Given this list of marker genes PIK3CG, TRPM4, ADORA1, DMD, ATP1B1, MIR1-1, PKP2, PLN, JPH1, GJA5, CAV3, TRDN, KCNQ1, JPH2, NPPA, GSTM2, SLC8A1, NOS1, ATP1A2, GATA4, HRC, CALM1, MIR200C (NCBI Gene Id 406985), DSG2, P2RX4, PDE4B, CALM2, CAMK2D, RNF207, PDE4D, STC1, ACE2, ATP2A2, ZC3H12A, FKBP1B, ADCY10 (NCBI Gene Id 82259), MYH7B, ASPH, CASQ2, ATP2A1, SUMO1, PRKACA, CAV1, KCNJ2, CACNA1C, HCN4, MIR30E, CALM3, STRIT1, FKBP1A, SRI, RGS2, AKAP9, DLG1, MYBPC3, RANGRF, SCN5A, MIR448, FGF13, CHGA, CLIC2, CTNNA3, ADRA1B, BMP10, SMAD7, GSTO1, DSC2, EHD3, TMEM38B, BIN1, RYR2, UCN, JPH4, HSP90AA1, SCN10A, DSP, MIR133A1, TNNI3K, NKX2-5, TNNI3, JUP, JPH3, SLC9A1, TMEM38A, ANK2, ADRA1A, here is a description of the gene set: Any process that modulates the frequency, rate or extent of cardiac muscle contraction. species: Homo sapiens Human Gene Set: GOBP_REGULATION_OF_CARDIAC_MUSCLE_CONTRACTION